Given this list of marker genes Atp5mc2, Atp5pd, Idh2, Dmac2l, Atp5mk, Atp5f1b, Atp5pf, Cycs, Gabpa, Atp5po (NCBI Gene Id 28080), mt-Atp8, Gabpb1, Atp5mc1, Sod2, Glud1, Sirt4, here is a description of the gene set: part of: Organelle biogenesis and maintenance studied in species Mus musculus electronically inferred by orthology from the curated human pathway Reactome Pathway: Mitochondrial biogenesis This event has been computationally inferred from an event that has been demonstrated in another species.<p>The inference is based on the homology mapping from PANTHER. Briefly, reactions for which all involved PhysicalEntities (in input, output and catalyst) have a mapped orthologue/paralogue (for complexes at least 75% of components must have a mapping) are inferred to the other species.